The following is a description of a gene set: The whole of the physical, chemical, and biochemical processes carried out by living organisms to break down ingested lipids into components that may be easily absorbed and directed into metabolism. Human Gene Set: GOBP_LIPID_DIGESTION studied in species Homo sapiens, and this is the list of marker genes: SOAT2, CYP8B1, APOA2, ENPP7, NPC1, LPCAT3, PNLIP, NPC1L1, PNLIPRP2, ABCG5, LEP, APOA1 (NCBI Gene Id 335), ARX, APOA4, CEL, AQP1, AKR1C1, ABCG8, ASAH2, LDLR, CD36, LIMA1